Given this list of marker genes IGFBP7 (NCBI Gene Id 3490), FRG1, CFI, CFH, EFEMP1, here is a description of the gene set: species: Homo sapiens Human Gene Set: HP_EXUDATIVE_RETINAL_DETACHMENT Exudative retinal detachment A type of retinal detachment arising from damage to the outer blood-retinal barrier that allows fluid to access the subretinal space and separate the neurosensory retina from the retinal pigment epithelium.